Given this list of marker genes GNPTAB (NCBI Gene Id 79158), PCGF3, MYG1 (MYG1 exonuclease), ACOT11, LINC02251, DNAH10, PSMD9, COL6A4P2, CD300A, OTUD7A, LRRC34P1, FBP2P1, TOM1, RBPJL, ADAP1, SYCE1, MFNG, MLPH, DHX40 (DEAH-box helicase 40, NCBI Gene Id 79665), ABCB1, PLCG2, IGFBP6, RN7SL472P, ATP5PDP1, SPACA3, EFHC1, COL6A3, BARX1, LINC02564, CLPS, FBXO38, LINC02136, STX8, here is a description of the gene set: from publication Yevshin I, Sharipov R, Kolmykov S, Kondrakhin Y, Kolpakov F (PMID 30445619) Genes containing one or more binding sites for (NKX6-1) in their promoter regions (TSS -1000,+100 bp) as identified by GTRD version 20.06 ChIP-seq harmonization. studied in species Homo sapiens Human Gene Set: NKX6_1_TARGET_GENES